The following is a description of a gene set: The chemical reactions and pathways involving purine deoxyribonucleoside triphosphate, a compound consisting of a purine base linked to a deoxyribose sugar esterified with triphosphate on the sugar. species: Homo sapiens Human Gene Set: GOBP_PURINE_DEOXYRIBONUCLEOSIDE_TRIPHOSPHATE_METABOLIC_PROCESS, and this is the list of marker genes: SAMHD1, NUDT15, ADA, NUDT16, ADK (adenosine kinase), DGUOK, GUK1